Given this list of marker genes BCL2L11, PAFAH1B1, DNAJB9, GRIA3, ITGA5, ERGIC2, CXXC5, GATA6, CPEB4, FOXG1, NOMO3, ITPR1, HYCC2, SCN3A, HAS3, RFX1, SIM2, COL1A2, EGR2 (early growth response 2), SPRYD4, PDS5B, FMN2, MYO1B, VPS54, ADAM10, GFPT2, MAN2A1, OGT, PKDCC, KAT2B, DSCAML1, CBFA2T3, PTGER4, GPR180, LATS2, PIK3AP1, P2RY13, GID4, CD69, PRDM13, CCNE2, DYNLT3, PPP1R12A, DUS2, HERPUD2, SIK1, FCHO2, NR4A3, RBM47, GPBP1L1, WRNIP1, GRHL1, GATAD2B, POLK, RNF4, MARF1, HHIP, PIKFYVE, FBN1, LBX1, BAZ2B, UBE2Z (ubiquitin conjugating enzyme E2 Z), SOBP, NRF1, MCL1, LUZP1, GAP43 (growth associated protein 43), FAM110B, FZD10, S1PR1, SNN, SERTAD3, WWP2, GOLGA8EP, FNIP1, SOX11, BCL11A, NFIB, CSMD3, CD2AP, MOAP1, MYCBP2, DUSP10, RNF44, FAM135A, GOLGA8G, ROBO2, BMPR2, LHFPL2 (LHFPL tetraspan subfamily member 2), C11orf24, HOXB8, SYN2 (synapsin II), ARRDC3, NFIA (NCBI Gene Id 4774), PRKCE, CHMP7, TSC1, ADAMTSL3, SCUBE3, SYNJ1 (NCBI Gene Id 8867), JOSD1 (Josephin domain containing 1), ELOVL4, LIN54, CDH10, CEP41, DDX3Y (NCBI Gene Id 8653), SRPRA, NLK (NCBI Gene Id 51701), CNEP1R1, ZFC3H1, LYST, IBTK, DPY30, NSMF, PCDH11Y, KALRN, APPL1, FBXW7, CREB1, PLEKHA6, NSMAF, RHPN2, UBE2W, NECAP1, KLHL14, DPP10 (dipeptidyl peptidase like 10), CIC, ZNF512B, PHLPP2 (NCBI Gene Id 23035), HERC2, YIPF4, PAX3 (paired box 3), PHTF2, BAZ2A, DOCK9, GOLGA8B, TRAF3, HIVEP1, DLGAP2, HAND2, ARID1B, LURAP1L, STK39, TMEM87A (transmembrane protein 87A), CCNC, KLHL18, BSDC1, EXOC5, SYNDIG1, FAM13B, GATA2, FHIP2A, FOXN2, NEFM, CBLN4, NPTX1, NOMO1, MACIR, FASLG, HCN2, SH3PXD2A, CCDC186, G3BP2, RSBN1, NOMO2, BCAT2, KIF5B, PCGF3, TRAK2, SMAD7 (SMAD family member 7), DYRK2, USP44, IQGAP2, PCDH11X, ARMC1, ATRX, ATXN3, EOMES, TULP4, CPEB2, PPP1R12C, ITPRID2, EPHA8, XYLT2, ARHGEF17, CLK3, GLYR1, SOX4, BRMS1L, ZNF711, ITGAV, KCNK10, BTG2, TECPR2, RGS17, RAD21, MORC3, TENT4A, CNNM4, PITPNC1, SLC38A2, OTUD4, DSC2, CDCA7L (NCBI Gene Id 55536), GOLGA4, USP28, PIP5K1C, ARRDC4, SESN3, ADM, CPEB3, CACNA1I, E2F3, TOB2, FNDC3B, SLC24A3, RGS3, SGPP1, CEBPA, SLC12A5 (solute carrier family 12 member 5), ZNF287, TEAD1, PTPRO, KLF2, DAB2IP, CDK16, TFDP2, GDF11, SLC17A6, RAB14, REV3L, SLC9A1, SLC32A1, PER2, PGAM4, COL12A1, RNF38 (NCBI Gene Id 64796), HNF1B, TEF, SDC2, GOLGA8A (NCBI Gene Id 23015), DCAF6, MED29, MARK1, GRAMD2B, PITPNA (NCBI Gene Id 5306), KMT5B, OAZ3, RAP1B, PPCS, NPTN, NOX4, NOVA1, UGP2, DNAJC30, TACC2, DMXL1, SMAD6, MYO18A, ANP32E, PDZD2, MAP2K4, DNAJB12, SOCS5, CXCL5, HAND1, LMBR1L, SERTAD2, BSN, NFAT5, LIN28B, FXR1, NFIX, SLX4, MYLIP, MYH9, TGIF1, EDEM1 (ER degradation enhancing alpha-mannosidase like protein 1), FMR1, ZDHHC5, FRY, TOB1, CDKN1C, TCF21, FHL2, TRAM2, TAFA1, RAB23, PIK3R3, RNF141, CREB3L2, TMEM184B, TRIO, CNTN4, FNBP4, KLF4, INSIG1, PGAM1, ERC2, ZEB2, RBPMS2, ADAM19, DDX3X, C6orf62, MEF2D, ATP2A2, PLEKHA1, ADCY3 (adenylate cyclase 3), RPS6KA4, TBL1XR1, here is a description of the gene set: Genes having at least one occurence of the motif GTGCAAT in their 3' untranslated region. The motif represents putative target (that is, seed match) of human mature miRNAs hsa-miR-25, hsa-miR-32, hsa-miR-92, hsa-miR-363 and hsa-miR-367 (v7.1 miRBase). Human Gene Set: GTGCAAT_MIR25_MIR32_MIR92_MIR363_MIR367 studied in species Homo sapiens